Given this list of marker genes SATB1, INO80D, TGFBR1 (NCBI Gene Id 7046), GNG12, ZC3H18, GPALPP1, MAP1B, TTC14, FZD8, TRIM10, PPP3CB, EBF1, COL4A3, EFNB1, EIF4A2, PAK5, RGL1, PARD3, ZNF804A, AFF4 (ALF transcription elongation factor 4), KIAA1549, VEZF1 (NCBI Gene Id 7716), PRSS12, ZHX1, ZCCHC4, FAM47B, MAPK10 (mitogen-activated protein kinase 10), CCDC6, MAPK8, NRG2, OMG, AFTPH, GPC5, ZFAND5, HSF5, LEKR1, GABRB2, NRIP1, CSNK2A1, LYSMD2, PMAIP1, RMI1, ITGB8, DDX3X, ACYP2, ZBTB41 (NCBI Gene Id 360023), KIAA1143, SCGB2A2, ARID5B, USP33, BTLA, ZDHHC15, SLC39A11, PTPRG, PCDHA2, SIAH2, RBMS3, CREBZF, METTL21A, EIF4G2, ITGA9, STAM, PROSER2, SYTL4, MAN1A1, ANKRD13C, PAK2, SECISBP2L, NBN, GPATCH2L, UBE2V2, PCDH9, ZC3H12C, ATP9A, PTGS2, RFX7, SLC4A8, SNX9, CDK8, ZNF106, DCUN1D5, CNTNAP2 (NCBI Gene Id 26047), PDE3B, MYH10, PODXL, MAX, CSNK1G3, SEC14L1, CNOT9 (NCBI Gene Id 9125), PTPDC1, ZNF677, PDCD4, ROR2, TMEM263, OSBPL8, WAPL, POLR3D, PLA2R1, MAL2, LXN, KLF12, EIF5, CAMTA1, ATP6V1C2, FEM1C, AMOT, NUS1, FAM220A, BCL2L11, SERPINB9, SEMA3A, SLC4A7, RRS1, ZNF519, CNTN1, DENND1B, IPO7, DEPDC1B (NCBI Gene Id 94594), RPIA, SMIM13, MMD (NCBI Gene Id 23531), ATXN3, SOX6, MYOZ2, DENND11, SBNO1 (strawberry notch homolog 1), BRAP, DBT, TRUB1, NCBP1, FAT1, SYT6, RELN, OTUD4, COL24A1, DAAM1 (NCBI Gene Id 23002), EFCAB14, LRRTM1, PRKACB (protein kinase cAMP-activated catalytic subunit beta), SNRK (SNF related kinase), USP44, LRRC8C, UTRN, PDE4D, MBNL3, MARCKS, METTL8, RAPGEF6, MRTFB, TCTN2, ARHGAP32 (Rho GTPase activating protein 32), KCNB1, FNIP1, RAD21, PUS10, GRIP1, STRN3, ELAVL4, RPS6KA4, SNX2, LRRC2, RIMS1, ERLIN2, C10orf88 (chromosome 10 open reading frame 88), RCOR1, TRPS1, KLHL32, GRK3, COLEC12, MAGEE1, CGGBP1, TMX1 (NCBI Gene Id 81542), NUFIP2, BRINP3, SRP72, B3GLCT, PPP6C, NEO1, KCNJ2, ROBO1, ENPEP, ZNF714, PALS1 (NCBI Gene Id 64398), PCSK2, APOOL, CYSLTR1, TNPO3, KLHL28 (kelch like family member 28), MARCKSL1, MINDY2, LPCAT2, SCN2B, LRATD2, EEIG2, DUSP3, BNC1 (NCBI Gene Id 646), ADAT2, PAM, B3GALNT2, PTPN4, RSPRY1, GBF1, SELENOP, MAL (mal, T cell differentiation protein), GNAQ, SRSF12, TNFRSF21, DOCK9, KDM5A, LHX6, KLHL8, WBP4, HP1BP3, STEAP4, TP53INP2, CNOT6, UBE2D3, KIF13B, APLN, SOS2, GEM, IL17RA, SERPINI2, USP37, RNF145, SETDB2, PRP4K, IRS2 (NCBI Gene Id 90066), STC1, CPED1, LAYN, TGFBR3 (NCBI Gene Id 7049), DDX5, NR4A3, PTGR1, TMEM47, DNAJC27, LRP6, ZEB1, LIN28B, ZRANB2, NCOR1, DOK6, IRX5, CDKL5, IFFO2, YWHAB, KPNA2, SDR42E1, NUP62CL, RPS6KB1, HOXB2, DTWD2, LRRC8B, MAPK8IP3, BDP1, SLC10A7, ZFHX3, ELOVL6, TLNRD1, here is a description of the gene set: Human Gene Set: MIR3617_5P Genes predicted to be targets of miRBase v22 microRNA hsa-miR-3617-5p in miRDB v6.0 with MirTarget v4 prediction scores > 80 (high confidence targets). from publication Chen Y, Wang X (PMID 31504780) species: Homo sapiens